Given this list of marker genes P2rx7, Glra2, P2rx1, Trpv1, Chrna4, Chrnd, Chrng, Gabrp, Chrna3, Glrb, Grik1, Grik3, Gabra5, Grin2d (glutamate receptor, ionotropic, NMDA2D (epsilon 4)), Chrnb3, Gabrb1, Gria2, Chrna9, Chrne, Chrna6, Grid1, Htr3a, Gabra6, Chrnb4, Slc17a7, Gabrg2, Htr3b, Chrnb1, Gabrd, Gabra3, Grin1, Grid2, Gabrr2, Gabrg1, Glra3, Gabrq, Chrna1, Grik4 (NCBI Gene Id 244825), P2rx3, Grin3b, Slc1a7, P2rx4, Chrna2, Gria4, Grik2, Chrm5 (NCBI Gene Id 278891), P2rx6, Gabrg3 (NCBI Gene Id 70716), Gabre, Gabra2, Grin2c, Grin3a, Glra4, Grin2a, Gria1, Gabrb3, P2rx5, Gabrb2 (NCBI Gene Id 78533), Glra1, Chrna7, Gabra4, Chrnb2, Chrna5 (NCBI Gene Id 11439), Gria3, Grin2b, Grik5, Chrna10, P2rx2, Gabrr1, Gabra1, here is a description of the gene set: Mouse Gene Set: GOMF_EXTRACELLULAR_LIGAND_GATED_MONOATOMIC_ION_CHANNEL_ACTIVITY studied in species Mus musculus Enables the transmembrane transfer of an ion by a channel that opens when a specific extracellular ligand has been bound by the channel complex or one of its constituent parts.